Given this list of marker genes PER1, NUMA1, CDH3, SMO, CLOCK, FA2H, KRT17, WNT10B, TGFB2, HPSE, PKP3, FOXN1, BMAL1, TRPV3, TSKU, WNT5A, TRADD, SMAD4, MYSM1, TNF, NGFR, DKK4, TERT, FERMT1, FST, MSX2, EPS8L3, NIPBL, GAL, here is a description of the gene set: studied in species Homo sapiens Any process that modulates the frequency, rate or extent of the cyclical phases of growth (anagen), regression (catagen), quiescence (telogen), and shedding (exogen) in the life of a hair. Human Gene Set: GOBP_REGULATION_OF_HAIR_CYCLE